Given this list of marker genes CDKN2C, GNA11, CASR, MEN1, AP2S1, GNAS, CDKN1B, KDM1A, GCM2, CDKN1A, CDKN2B (NCBI Gene Id 1030), CDC73, ARMC5, YY1, here is a description of the gene set: studied in species Homo sapiens Human Gene Set: HP_PRIMARY_HYPERPARATHYROIDISM A type of hyperparathyroidism caused by a primary abnormality of the parathyroid glands (e.g., adenoma, carcinoma, hyperplasia). Primary hyperparathyroidism is associated with hyercalcemia. Primary hyperparathyroidism